The following is a description of a gene set: Human Gene Set: GOBP_PYRIMIDINE_NUCLEOSIDE_MONOPHOSPHATE_METABOLIC_PROCESS species: Homo sapiens The chemical reactions and pathways involving pyrimidine nucleoside monophosphate, a compound consisting of a pyrimidine base linked to a ribose or deoxyribose sugar esterified with phosphate on the sugar., and this is the list of marker genes: CDA, UCK1, UCK2, UPP2, DCK, UPB1, NT5M, CAD, TYMS, DCTD, DHODH, CMPK1 (NCBI Gene Id 51727), TYMP, DUT, SHMT1, NT5C, UPP1, DPYS, UPRT (NCBI Gene Id 139596), UCKL1, UMPS, DPYD